The following is a description of a gene set: Genes up-regulated in CD4 T cells with NRAS knockout: unstimulated versus activated. studied in species Homo sapiens Human Gene Set: GSE45739_UNSTIM_VS_ACD3_ACD28_STIM_NRAS_KO_CD4_TCELL_UP from publication Lynch SJ, Zavadil J, Pellicer A (PMID 23755101) It has been recently shown that N-ras plays a preferential role in immune cell development and function; specifically: N-ras, but not H-ras or K-ras, could be activated at and signal from the Golgi membrane of immune cells following a low level TCR stimulus. The goal of our studies was to test the hypothesis that N-ras and H-ras played distinct roles in immune cells at the level of the transcriptome. First, we showed via mRNA expression profiling that there were over four hundred genes that were uniquely differentially regulated either by N-ras or H-ras, which provided strong evidence in favor of the hypothesis that N-ras and H-ras have distinct functions in immune cells. We next characterized the genes that were differentially regulated by N-ras in T cells following a low-level TCR stimulus. Of the large pool of candidate genes that were differentially regulated by N-ras downstream of TCR ligation, four genes were verified in qRT-PCR-based validation experiments as being differentially regulated by N-ras (Dntt, Slc9a6, Chst1, and Lars2). Finally, although there was little overlap between individual genes that were regulated by N-ras in unstimulated thymocytes and stimulated CD4+ T-cells, there was a nearly complete correspondence between the signaling pathways that were regulated by N-ras in these two immune cell types. Since we were interested primarily in genes that were differentially regulated by N-ras following a low-level TCR stimulus, our microarray data comparison was between data from TCR-stimulated, WT CD4+ T-cells and from TCR-stimulated, N-ras KO CD4+ T-cells. Genes that were differentially regulated in the comparison between stimulated N-ras KO CD4+ T-cells and unstimulated N-ras KO CD4+ T-cells, as well as those genes that were differentially regulated in the comparison between stimulated WT CD4+ T-cells and unstimulated WT CD4+ T-cells were excluded from this analysis. To determine if N-ras and H-ras regulate different sets of genes in thymocytes, a comparison was made between the set of genes that were differentially regulated by N-ras in the vs. comparison and the set of genes that were differentially regulated by H-ras in the vs. comparison., and this is the list of marker genes: STAT5B, DALRD3 (DALR anticodon binding domain containing 3), SVIL, GRSF1, NECAP2, SERINC5, MCUB (mitochondrial calcium uniporter dominant negative subunit beta), SYNE3, DEAF1, ITGA6, ICOS, SSBP1, LETMD1, PSIP1, CD5, C2CD5, ARHGAP15, EPHX2, TRAV8-3, MAL, TARDBP (TAR DNA binding protein), ZNF512B, MEOX1, CACNA1I, ST8SIA1, IL6ST, LDHB, PLSCR3, LPIN2, CYLD, LY96, IGBP1, FBXL8, SSBP2, ST13, CSGALNACT1, CDC14A, FAM13A, PAICS, TRAC, DYRK2, PLCL1, CRYBG3, REXO2, LANCL1, TENT4A, CREBZF, DPP4, AMMECR1, FRY, ADPRM, CD28, PRPSAP2, LIMS2, FLT3LG, UBQLN2, GALT, MAST4, PTCD3, TRPC1, VPS8, RNASET2, PARP12, TACC3, CBX7, CFP, PIGC, MICAL1, MLLT3, EPHB6, LIMS1, GPR183, TPCN1 (two pore segment channel 1), FHL1, TRAT1, PDE4DIP, IL11RA, NUP85, CAMK4, MORC4, EDEM1, DIDO1, UXS1, SYNJ1, FYB1, ASXL1, PRKCA, CYSLTR1, LEF1, EXOC1, RFNG, TRAK2, RERE, PRORP, AP3M2, AQP3, GPA33, MORC2, GABBR1, MX2, CEP68, WDR59, APBB3, RCAN3, DBP, GNAQ, ACYP2, LTBP3, PCMTD2, LTB, MSL3, MALT1, FCGRT, MFHAS1, GARRE1, FHIT, TCF7, DGKA, MEIS3P1, DAP3, ENTPD4, LPAR6, GOLGA8B, RAB3GAP1, GORASP1, GSTK1, CORO1B, STX16, PMM1, ANKRD55, NEMP1, TRADD, KRT18, SPG7, KLHL3, NOSIP, LINS1, ORC3, COMMD3, CD40LG, PCYOX1L, KCTD3, NOL9, CCNL2, PHF10, NUP50, MDFIC, ENOSF1, BAG3, PDK1, N4BP2L2, TMEM131L, HAUS4, MKRN1, F5, TRDV2, SPTBN1, CTLA4, INPP4B (NCBI Gene Id 8821), TTC12, EDAR, TNFRSF25 (TNF receptor superfamily member 25), IFI44, CUTC, ARID5B, IL6R, ARHGEF11, ADSL, HADHB, SOD1, LGALS3BP, ANP32B, ADI1, HSPB1, CTSB, TENM1, ACVR1, TLK1, ZBTB14, ANK3, MAP3K1, NFRKB, INPP5A, TESPA1, PLP2, TRIB2, UBR4, DENND5A, PHC1, BEX3, ATP5PD, DEF6 (NCBI Gene Id 50619), TBC1D4, VIPR1, FUBP1, PPWD1, ZFC3H1, NEFL, NET1, SLC7A6